The following is a description of a gene set: Absence or underdevelopment of the cerebral white matter. Aplasia/Hypoplasia of the cerebral white matter species: Homo sapiens Human Gene Set: HP_APLASIA_HYPOPLASIA_OF_THE_CEREBRAL_WHITE_MATTER, and this is the list of marker genes: PIGA, MT-CO2, MT-CO3, TMX2, MT-ND1, MT-CO1, ZEB2, MT-TW, MT-TF, WARS2, MT-ND6, SLC2A1, MT-TH, PSAT1, MT-ND5, MT-TS2, MT-TQ, MT-TL1, FDXR, STRADA, RNU4-2, NACC1, KDM1A, MT-ND4, NARS1